The following is a description of a gene set: Aplasia/Hypoplasia of the spleen Human Gene Set: HP_APLASIA_HYPOPLASIA_OF_THE_SPLEEN Absence or underdevelopment of the spleen. species: Homo sapiens, and this is the list of marker genes: DNAL1, DNAH1, CFAP300, NODAL, TMEM237, B9D1, ZIC3, DNAAF5, STRA6, TMEM67, NME5, MCM10, SPEF2, CFAP74, DNAI2, CEP290, KLF1, B9D2, MNS1, CLXN, RSPH4A, DNAH5, NEK10, KATNB1, DNAH11, AIRE, CCDC40, STK36, TMEM107, DNAAF11, CFAP298, RSPH3, FAM111A, MCIDAS, OFD1, HBG2, TMEM216, NPHP3, TTC12, CFC1, CCDC32, RPGRIP1, FOXF1, HBG1, CCDC39, CCNO, ODAD2, MYCN (NCBI Gene Id 53360), HYDIN, RSPH1, RPSA, DRC1, TMEM231, ZMYND10, RSPH9, STIM1, DNAAF1, BCL11A, ODAD1, DNAJB13, LRRC56, NEK8, DNAH9, DNAI1, HMOX1, TCTN3, WNT3, GDF1, TXNDC15, RPGRIP1L, DNAAF3, RPGR, NME8, CFAP221, FOXJ1, DNAAF2, TCTN1, RELN, SPAG1, SAMD9, ZEB2, SMAD2, NDE1, CC2D2A (coiled-coil and C2 domain containing 2A), MKS1, ODAD4, TCTN2, GAS2L2, DNAAF6, ORAI1, HBB, TWIST1, CSPP1, DNAAF4, ODAD3